Given this list of marker genes TRIM10, APOBEC3H, PIK3C2G, IFNA2, TMEM41B, FBXL2, LEF1, HDAC1, NAPEPLD, TRIM26, F2RL1, EIF2AK4, CARD9, PRKN, PC, FCN3, IFITM1, SP1, MIR130A, TRIM59, ARG1, SLPI, TBC1D20, RAB29, HPN, VAPB, LY6E, TRIM8, RAB5A, PAIP1, STOM, TRIM25, REST, CD74, CCNT1, IGF2R, SMARCA4, PSMC3, ZDHHC8, SNW1, CFL1, PI4KA, ZC3H12A, NOD2, EP300, ZNF639, SNX3, JUN, PPIB, CAV2, PRF1, IFITM3, FBLN1, IFI27, CCL5, TRIM11, CIITA, SMC5, CXCL6, MUC2, IFITM2, POMC, FASN, VAPA, PIK3C3, TARDBP (NCBI Gene Id 81927), EPG5, MIR222, APCS, GALP, CDK9, ZNF502, CSF1R, MIR30C1, NUCKS1, ZDHHC9, EEF1A1 (eukaryotic translation elongation factor 1 alpha 1), MIR221, SMC6, LRRC19, TMEFF1, ROCK2, CCL3, TRIM31, CCNK, POU2F3, MIR141, PHB1, TRIM5, YTHDC2, MID2, CCNT2, CCL4, RRP1B, ZFYVE1 (zinc finger FYVE-type containing 1), GSN (NCBI Gene Id 2934), CTDP1, HMGA2, ZDHHC20, TAF11, CDC42, TFAP4, FCN1, PPARA, APOE (NCBI Gene Id 99), FMR1, LRRC15, CAMP, SMARCB1, NLRP6, CX3CR1, PTX3, CCL8, CHD1, LTF, INPP5K, SPRR2A, DDX56, BRD4, ST6GALNAC1, ZBED1 (NCBI Gene Id 9189), EEA1, here is a description of the gene set: Human Gene Set: GOBP_MODULATION_OF_PROCESS_OF_ANOTHER_ORGANISM species: Homo sapiens A process in which an organism effects a change in a biological process in another organism.